Given this list of marker genes CCDC32, PIGG, ZIC3, ODAD4, GDF1, CHD6, TBX5, FOXJ1, CFAP52, KDM3B, CTBP1, NSD2, CFC1, CLXN, CFAP53, SMAD2, CCDC39, DAW1, PKD1L1, LETM1, NELFA, NEK10, DNAAF5, CIROP, MMP21, CPLX1, FANCB, NODAL, ACTG2 (NCBI Gene Id 72), DNAH9, here is a description of the gene set: An abnormality in which the internal thoraco-abdominal organs demonstrate abnormal arrangement across the left-right axis of the body. Heterotaxy Human Gene Set: HP_HETEROTAXY studied in species Homo sapiens